Given this list of marker genes Ezh2, Rnf8, Eapp, Recql5, Nelfb, Nelfe, Nelfa, Nelfcd, Shh (NCBI Gene Id 20423), Hexim1 (NCBI Gene Id 78504), Rnf168, Hnrnpu, Axin1, Sirt6, Supt4a, Parp1, here is a description of the gene set: Any process that stops, prevents, or reduces the frequency, rate or extent of transcription elongation, the extension of an RNA molecule after transcription initiation and promoter clearance by the addition of ribonucleotides, catalyzed by RNA polymerase II. studied in species Mus musculus Mouse Gene Set: GOBP_NEGATIVE_REGULATION_OF_TRANSCRIPTION_ELONGATION_BY_RNA_POLYMERASE_II